Given this list of marker genes Bmp5, Nkx3-1, Atxn7, Atxn1, Inppl1, Cilp, Igfbp5, Trim72, Bmp2, here is a description of the gene set: studied in species Mus musculus Any process that stops, prevents, or reduces the frequency, rate or extent of insulin-like growth factor receptor signaling. Mouse Gene Set: GOBP_NEGATIVE_REGULATION_OF_INSULIN_LIKE_GROWTH_FACTOR_RECEPTOR_SIGNALING_PATHWAY